Given this list of marker genes ACTG1, PIK3CD, PIK3CA, CYTH2, ARPC5, ARPC5L, ACTR3, ARF1, CYFIP1, ARPC2, ARPC3, PIK3C2B, ACTB, WASF2, ARPC1B, WASF1, BRK1, CYTH4, ARPC4, PIK3CG, ABI1, CYTH3, CYTH1, PIK3CB, ARPC1A, NCKAP1, ARF6, ACTR2, WASF3 (NCBI Gene Id 10810), CYFIP2, here is a description of the gene set: Salmonella SopB to ARNO-ARF-ACTB/G signaling pathway. Pathway ID: N01129. Pathway type: Pathogen. Pathway class: nt06135 Cytoskeletal regulation (viruses and bacteria). Human Gene Set: KEGG_MEDICUS_PATHOGEN_SALMONELLA_SOPB_TO_ARNO_ARF_ACTB_G_SIGNALING_PATHWAY Pathway Definition from KEGG: SopB -> (PIK3CA/B/G/D,PIK3C2B) -> PIP3 -> ARNO -> ARF6 -> ARF1 -> (WASF+ABI1+HSPC300+CYFIP+NCKAP1) -> ARP2/3 -> (ACTB,ACTG1) studied in species Homo sapiens